The following is a description of a gene set: species: Homo sapiens Reactome Pathway: Degradation of GLI2 by the proteasome part of: Hedgehog 'off' state The primary role of the GLI2 protein is as an activator of Hh-dependent signaling upon pathway stimulation; in the absence of Hh ligand, a small fraction of GLI2 appears to be processed to a repressor form, but the bulk of the protein is completely degraded by the proteasome. Both the processing and the degradation of GLI2 is dependent upon sequential phosphorylation of multiple serine residues by PKA, CK1 and GSK3, analagous to the requirement for these kinases in the processing of GLI3. The differential processing of GLI2 and GLI3 depends on the processing determinant domain (PDD) in the C-terminal of the proteins, which directs the partial proteolysis of GLI3 in the absence of Hh signal. Substitution of 2 amino-acids from GLI3 into the GLI2 protein is sufficient to promote efficient processing of GLI2 to the repressor form., and this is the list of marker genes: PSMD2, PRKACG, PSMB1, PSMD12, PSMC2, RBX1, CUL1, PSMC1 (NCBI Gene Id 5700), PRKACB, PSMA4, SEM1, PSMC3, PSMD1, PSMA1, GSK3B, GLI2, PSMB6, UBA52, PSMA3, PSMD14, SKP1, PSMD3, PSMA6, PSMB5, PSMA7, PSMD11, PSMB7, RPS27A, BTRC, PRKACA, PSMD7, PSMA5, PSMC6, PSMD8, SUFU, PSMC4, UBC, PSMC5, PSMB2, CSNK1A1, PSMD6, PSMB4, ADRM1, PSMB3, PSMD13, UBB, PSMA2